The following is a description of a gene set: POU5F1 (OCT4), SOX2, and NANOG bind elements in the promoters of target genes. The target genes of each transcription factor overlap extensively: POU5F1, SOX2, and NANOG co-occupy at least genes. About half of POU5F1 targets also bind SOX2 and about 90% of these also bind NANOG. Upon binding the transcription factors activate expression of one subset of target genes in the core transcriptional network of pluripotent stem cells and repress another subset. The target genes listed in this module are the repressed genes. Caution must be used when making inferences about human stem cells from mouse stem cells because of significant differences between the two species. studied in species Homo sapiens part of: Transcriptional regulation of pluripotent stem cells Reactome Pathway: POU5F1 (OCT4), SOX2, NANOG repress genes related to differentiation, and this is the list of marker genes: HHEX, POU5F1 (NCBI Gene Id 7934), CDX2, GSC, GATA6, SOX2, DKK1, EOMES, TSC22D1, NANOG